Given this list of marker genes POGLUT1, POGLUT3, GYG2, POGLUT2, GYS1, UGGT1, EPM2A, GYG1, ALG5, UGGT2, GYS2, UGCG, here is a description of the gene set: Human Gene Set: GOMF_UDP_GLUCOSYLTRANSFERASE_ACTIVITY Catalysis of the transfer of a glucosyl group from UDP-glucose to an acceptor molecule. species: Homo sapiens